Given this list of marker genes IRS2, INS, MAPK3, SHC1, GRB2, SOS1, IRS1, MAPK1, GRB10, INSR, here is a description of the gene set: Reactome Pathway: Signal attenuation species: Homo sapiens Now with the complete receptor-ligand dissociation and subsequent degradation of insulin in the endosomal lumen, the endosomally associated protein tyrosine phosphatases (PTPs) complete the receptor dephosphorylation. So too are all the receptor substrates dephosphorylated leading to the collapse of the signalling complexes and signal attenuation. part of: Insulin receptor signalling cascade